The following is a description of a gene set: The terminal specialization of a calyciferous axon which forms large synapses in the mammalian auditory central nervous system. species: Mus musculus Mouse Gene Set: GOCC_CALYX_OF_HELD, and this is the list of marker genes: Calm1, Calb1, Cplx2, Tprg1l, Prkca, Septin5, Prkcb, Kcna3 (potassium voltage-gated channel, shaker-related subfamily, member 3), Glra1, Kcnc3, Kcna2, Kcnc4, Atp1a3, Kcna1, Kcnk2, Aak1, Htr1b, Kcnq5 (potassium voltage-gated channel, subfamily Q, member 5), Itsn1, Tspoap1, Calm2, Nos1, Calm3, Cplx1, Adora1, Unc13b, Git2, Rimbp2, Actb, Prkcg, Ncs1, Unc13c, Unc13a, Git1, Kcnc1, Actg1